Given this list of marker genes SLC4A4, here is a description of the gene set: part of: SLC transporter disorders species: Homo sapiens Members 4, 5, 7 and 9 of the SLC4A family couple the transport of bicarbonate (HCO3-) with sodium ions (Na+). SLC4A4 (aka NBCe1) is an electrogenic Na+/HCO3- cotransporter with a stoichiometry of 1:3. SLC4A4 is expressed in the kidney and pancreas, with lesser expression in many other tissues. Mutations in SLC4A4 can cause permanent isolated proximal renal tubular acidosis with ocular abnormalities and mental retardation (pRTA-OA), a rare autosomal recessive syndrome characterised by short stature, proximal renal tubular acidosis, mental retardation, bilateral glaucoma, cataracts and bandkeratopathy. pRTA results from the failure of the proximal tubular cells to reabsorb filtered HCO3- from urine, leading to urinary HCO3- wasting and subsequent acidemia. HCO3- also needs to move out of cells in the eye, thus failure to do so can affect ocular pressure homeostasis. Reactome Pathway: Defective SLC4A4 causes renal tubular acidosis, proximal, with ocular abnormalities and mental retardation (pRTA-OA)